Given this list of marker genes Ptchd1, Map3k12, Prpf4b, Zbtb18, Ak7, Pcnx1, Lrch1, Mier3, Jpt1, Fmr1, Ivd, Negr1, Kctd10, Rfx6, Tead1, Glra2, Stmn1, Eid1, Npy1r, Tppp (tubulin polymerization promoting protein), Mastl, Btf3l4, G3bp2, Hdac8, Sumf1, Tmx4, Ikzf2, Tfdp1, Isl1, Card10, Myt1l, Rora, Pou3f3, Selenot, Sptbn1, Ppp2ca, Rc3h2, Zc3h12c (zinc finger CCCH type containing 12C), Apbb2, Elavl4, Rbm26, Map3k11, Cited2, Sh3bp5, Btbd2, Maf, Dyrk1a, Rnf44, AU040320 (NCBI Gene Id 100317), Arid4b, Map3k2, Esrrg, Ranbp17, Cask, Rc3h1, Elp4, Kcnj2, Idua, Nr2c2, Rabgap1, Kif13a, Mxd3, Sgsm2, Rap2c, Spg11, Pnp, Ppp6r3, Rad21, Vsnl1, Stx7, Galnt13, Rragd, Nploc4, Vps26a, Pals1, Eqtn, Vwc2l, Zfp14, Skida1, Fkbp1b, Hif1a, Kdm2b, Ago3, Ddx55, Glce, Rufy2, Slc7a2, here is a description of the gene set: studied in species Mus musculus Mouse Gene Set: MIR_143_5P Genes predicted to be targets of miRBase v22 microRNA mmu_miR_143_5p in miRDB v6.0 with MirTarget v4 prediction scores > 80 (high confidence targets). from publication Chen Y, Wang X (PMID 31504780)